Given this list of marker genes CDT1, KCTD1, TP63, DYRK1A, ORC1, ESR1, ORC4, CDC45, TBX3, ORC6, CDC6, PLXND1, IKBKG (NCBI Gene Id 8517), TWIST2, GMNN, LMNA, REV3L, here is a description of the gene set: Human Gene Set: HP_BREAST_APLASIA Failure to develop and congenital absence of the breast. species: Homo sapiens Breast aplasia